Given this list of marker genes Tsc2, Cd24a, Clip1, Reep2, Umod, Rftn1, here is a description of the gene set: Mouse Gene Set: GOBP_PROTEIN_TRANSPORT_INTO_MEMBRANE_RAFT The directed movement of a protein into a membrane raft. Membrane rafts are small (10-200 nm), heterogeneous, highly dynamic, sterol- and sphingolipid-enriched membrane domains that compartmentalize cellular processes. studied in species Mus musculus